The following is a description of a gene set: Abnormally increased curvature (anterior concavity) of the lumbar or cervical spine. studied in species Homo sapiens Hyperlordosis Human Gene Set: HP_HYPERLORDOSIS, and this is the list of marker genes: COL12A1, COL11A2, HNRNPA2B1, FLNB, TRAPPC11, AHDC1, FKRP, MYH7, ARSK, MAP3K20, MYBPC1, SELENON, MTMR14, POMT2, IHH, POLR3GL, EIF2AK3, GARS1, SETBP1, FUCA1, TFAP2A, H4C5, PIK3CD, BCR, RERE, HSPG2, DYSF, MED12, GFPT1 (glutamine--fructose-6-phosphate transaminase 1), ADAMTS10 (ADAM metallopeptidase with thrombospondin type 1 motif 10), PUS1, TMEM43, MMP13, STX1A, CAVIN1, VAC14, ALG2, CLIP2, FRG1, MASP1, SYNE1, TTN, MAPK1, SYNE2, CTSK, TRAPPC2, SNUPN, FBN1, LIMK1, ZC4H2, POP1, SPTLC1, BGN, OBSL1, LMNA, ADNP, TPM2, SPEG, SMAD4, CLCF1, HNRNPH2, GSC, DPAGT1, HNRNPA1, AP1G1, SGCG, VPS13B, TRPV4, FKBP6, NPR2, RAB3GAP1, TWIST1, ELN, FN1, NSDHL, WNK1, GNB2, NEB, PRG4, L1CAM, PIK3C2A, RFC2, DNAJC30, DNA2, EIF4H, GNPTAB, TMEM270, HERC1, COL6A1, AMER1 (NCBI Gene Id 160176), VCP (NCBI Gene Id 94731), SMARCAL1, KIF1A, DUX4L1, KY, ITCH, ALG14, SYT1, FGFR3, PCGF2, ASCC3, POMK, TAF4, DYM, CCN6, INPP5K, FHL1, DNM2, RMRP, KLHL41, TPM3, PPM1D, EMD, COL6A3, LMX1B, CCDC8, PIEZO2, BUD23, SGCA, VPS33A, CSGALNACT1, TNNT1, EXTL3, DAG1, CAPN3 (calpain 3), PLEC, ACTA1 (actin alpha 1, skeletal muscle, NCBI Gene Id 58), NAA10, ACP5, SLC10A7 (solute carrier family 10 member 7), DMD, CFL2, GLB1, COLQ (collagen like tail subunit of asymmetric acetylcholinesterase), LTBP1, POMT1, NCF1, GTF2IRD2, GTF2IRD1, POMGNT1, EBF3, XYLT1, GMPPB, TFE3, MYL2, COL27A1, ACAN, FKTN, SON, SCN4A, MUSK, PPP1R15B, MEGF10, LAMA2, PRKG2, SCN9A, LBR, NECTIN1, CRKL, TMEM63C, COL2A1, RTN2, ITGA7, COL1A2, ABCC9, LMOD3, RAB3GAP2, MAPK8IP3, DNMT3B, TBX6, MYPN, KNSTRN, CUL7 (cullin 7), RSPRY1, CANT1, DDRGK1 (DDRGK domain containing 1), TONSL, TBL2, COLEC10, GNPNAT1, COL6A2, NF1, BICD2, SMCHD1, TRPS1, PLAAT3, TGFB1, COL10A1, ALX3, BIN1, HACD1, DUX4, IARS2, RETREG1, SHOX, METTL27, RAB33B, BCOR, KANSL1, BAZ1B, FGFR2, SATB2, GALNS, SETD5, MATN3 (NCBI Gene Id 4148), GTF2I, MFN2, RYR1, TOR1A, COMP, COLEC11, PLEKHG5, NOTCH3, CHST3 (carbohydrate sulfotransferase 3), ASH1L, SOX5, VPS37D, HACE1, RET, TOGARAM1, ARSB, SLC26A2, GNPTG, ECEL1, CHST11, LIPE